Given this list of marker genes ahpC, secY, secG, sodC, secA1, secA2, secD, secE, secF, sodB, katG, here is a description of the gene set: part of: Latent infection - Other responses of Mtb to phagocytosis The expression of <i>AhpC</i> in Mycobacteria does not correlate with virulence; instead, the most important parts of the antioxidant system in <i>Mtb</i> appear to be the lipid cell wall, the enzymes SodB/SodC (superoxide dismutases), and the catalase/peroxidase KatG. Together with the enzyme system that acts on nitrosative stress and the sequestration of iron, these appear to be critical in defending against the macrophage's production of ROS/RNS, and enable the bacterium to exist in the phagosome for extended periods (Zahrt & Deretic 2002). studied in species Homo sapiens Reactome Pathway: Tolerance of reactive oxygen produced by macrophages